The following is a description of a gene set: from publication Chen Y, Wang X (PMID 31504780) species: Mus musculus Genes predicted to be targets of miRBase v22 microRNA mmu_miR_138_2_3p in miRDB v6.0 with MirTarget v4 prediction scores > 80 (high confidence targets). Mouse Gene Set: MIR_138_2_3P, and this is the list of marker genes: Twf1, Aktip, Lrrc4c, Svs3b, Trps1, Tab1, Ino80d, 2510039O18Rik, Cct7, Scai, Carnmt1, Nufip2, Xlr4a, Mypn, Tdrd3, Serinc1, Adamts12, Zfp746, Dab1, Phf21a, Pde6d, Rnf169, Rtp4, Trpc1, Xlr4c, Pnisr, Cxxc5, Ltbp3, Purb, Gpr173 (G-protein coupled receptor 173), Slfn14, Steap2, Lrba, Ankle2, Crebzf, Gabra5, Kif11, Slitrk2, Sike1, Rnf146, Agfg1, Cx3cr1, Zbtb41, D630023F18Rik, Ankrd28, Slc7a3, Epha5, Rcn2 (NCBI Gene Id 27014), Tmx3, Nsd3, Twsg1 (NCBI Gene Id 71539), Myg1, Slc17a6, D3Ertd751e, Slc35a5, Fbxl17, Mef2c, Azin1, Xlr4b, Focad, Kif3a (kinesin family member 3A), Dcx, Cdc123, Vti1a, Faxc, Plcb1, Mbd5, Ivns1abp, Zfhx3, Dda1, Steap4, Nphs1, Dvl2, Taf4b, Kctd14, 1600014C23Rik, Insc, Tm9sf3, Erbb4, Ryr3, Tm4sf20, Tril, Qng1, Uba6, Slc39a9, Phospho2 (NCBI Gene Id 99246), Pou4f2, Ago4 (argonaute RISC catalytic subunit 4), Dnal1, Ppp1r17, St8sia4, Zfp367, Tll1, Ppfia2, Rgs9, Zfp385b, Nanp, Ptger4, Ecd, Phip, Vdac2, Golim4, Ccdc169, Rps6kb1, Esyt2, Zbtb33, Ugt2b1, Ccdc80, Ptf1a, Tbr1, Zfhx4, Ctnnd2, Tmem72